Given this list of marker genes Henmt1 (HEN1 methyltransferase homolog 1 (Arabidopsis)), Mettl16 (NCBI Gene Id 76970), Mettl6, Prdm1, Mettl21c, Prmt7, Larp7-ps, Trmt1, Trmt44, Prmt5, Rab3d, Mrm2, Prmt8, Btg1, Slc25a26, Rab6a, Trmt10b (tRNA methyltransferase 10B), Mettl22, Setd2, Rnmt, Kmt5a, Nsun3, Emg1, Trmt13, Trmt1l, Hsd17b10, Mettl18, Trdmt1, Mettl14, Gtpbp3, Tyw3, Mto1, Snrpb, Btg2, Mettl1, Fbll1, N6amt1, Wdr6, Trmo, Zcchc4, Carm1, Ramac, Gm15222, Fam98b, Snrpd3, Antkmt, Kmt2a, Camkmt, Lcmt1, Rbm15b, Smyd2, Dalrd3, Lcmt2, Bud23, Tfb2m, Alkbh8, Dimt1, Rab3b, Bcdin3d (BCDIN3 domain containing), Mrm1, Mettl8, Ntmt2, Eef1akmt3, Nop2, Wdr4, Pcmt1 (protein-L-isoaspartate (D-aspartate) O-methyltransferase 1), Trmt10c, Nsun2, Prdm12, Trmt9b, Mrm3, Setd7, Trmt2b, Mettl21a, Nsun4, Ntmt1, Trmt6, Eef2kmt, Comt, Tarbp1, Trmt12, Eef1akmt2, Etfbkmt, Thada, Gspt1, Ehmt2, Ndufaf7, Akt1, Mettl3, Icmt, Mettl5, Trmt10a, Larp7, Vcpkmt, Ftsj1, Trmt5, Ehmt1, Setd3, Nsun5, Tgs1, Fbl, Prmt1, Ilf3, Mepce, Mettl2, Fam98a, Nsun6, Eef1akmt1, Etf1 (NCBI Gene Id 52117), Rbm15, Mettl15, Thumpd2, Trmt61a, Thumpd3, Tfb1m, Setd6, Atpsckmt, Trmt112, Ftsj3, Wdr5, Fdxacb1, here is a description of the gene set: The covalent attachment of a methyl residue to one or more monomeric units in a polypeptide, polynucleotide, polysaccharide, or other biological macromolecule. Mouse Gene Set: GOBP_MACROMOLECULE_METHYLATION species: Mus musculus